The following is a description of a gene set: Mouse Gene Set: GOBP_SPERM_DNA_CONDENSATION The progressive compaction of the spermatid chromatin so that it reaches a level of condensation that is not compatible with nuclear activities such as transcription or DNA replication. studied in species Mus musculus, and this is the list of marker genes: Gm773, Sycp3, Prm1, Tnp1, Tssk6, Kat5, Selenof, Brdt, Fshr, H2al2a (H2A histone family member L2A), Rnf8, Psme4, Sycp1, Piwil1, Chd5, H2bc1, Epc1, H1f7, Tnp2